Given this list of marker genes LRRC3, PLD4, CLEC3B, C3orf86P, TTLL1, CDH26, FLNB, CDKN1C, GOLGA8N, AZU1, ACTL10, RNU6-1, RETN, C2orf74, PRR22, PMP22, here is a description of the gene set: Systems biology is an approach to comprehensively study complex interactions within a biological system. Most published systems vaccinology studies have utilized whole blood or peripheral blood mononuclear cells (PBMC) to monitor the immune response after vaccination. Because human blood is comprised of multiple hematopoietic cell types, the potential for masking responses of under-represented cell populations is increased when analyzing whole blood or PBMC. To investigate the contribution of individual cell types to the immune response after vaccination, we established a rapid and efficient method to purify human T and B cells, natural killer (NK) cells, myeloid dendritic cells (mDC), monocytes, and neutrophils from fresh venous blood. Purified cells were fractionated and processed in a single day. RNA-Seq and quantitative shotgun proteomics were performed to determine expression profiles for each cell type prior to and after inactivated seasonal influenza vaccination. Our results show that transcriptomic and proteomic profiles generated from purified immune cells differ significantly from PBMC. Differential expression analysis for each immune cell type also shows unique transcriptomic and proteomic expression profiles as well as changing biological networks at early time points after vaccination. This cell type-specific information provides a more comprehensive approach to monitor vaccine responses. Human Gene Set: HOEK_MONOCYTE_2011_2012_TIV_ADULT_1DY_DN Genes down-regulated in monocyte 1d vs 0d in adults after exposure to 2011-2012 trivalent inactivated vaccine (A/California/7/09 (H1N1), A/Perth /16/2009 (H3N2), B/Brisbane/60/2008), time point 1D. Comment: Down-regulated DE RNA transcripts (down >= 1.5x) shared between both TIV-vaccinated donors from publication Hoek KL, Samir P, Howard LM, Niu X, Prasad N, Galassie A, Liu Q, Allos TM, Floyd KA, Guo Y, Shyr Y, Levy SE, Joyce S, Edwards KM, Link AJ (PMID 25706537) studied in species Homo sapiens